Given this list of marker genes AURKA, CPAP, HAUS5, TUBG1, ALMS1, HAUS7, HAUS4, CEP78, CLASP1, CCP110, CEP76, CEP135, NDE1, CEP131, YWHAE, AKAP9, CEP41 (NCBI Gene Id 95681), DYNLL1, CNTRL, CDK5RAP2, TUBB4A, HAUS1, HAUS2, TUBB4B, CEP57, ACTR1A, NINL, PRKACA, NEK2, CEP70 (NCBI Gene Id 80321), YWHAG, CDK1, PLK4, ODF2, CEP192, CSNK1E, CETN2, SSNA1, CSNK1D, DCTN1, PAFAH1B1, MAPRE1, NEDD1, CEP290, PPP2R1A, CEP43, PCNT, DYNC1H1, CEP164, TUBA4A, PCM1 (pericentriolar material 1), HMMR, CEP63, HAUS3, TUBB, HSP90AA1, HAUS8, OFD1, PLK1, DCTN3, HAUS6, DCTN2, PRKAR2B (NCBI Gene Id 5577), CEP250, CEP152, CKAP5, DYNC1I2, TPX2, CEP72 (NCBI Gene Id 55722), TUBA1A, SFI1, SDCCAG8, here is a description of the gene set: Reactome Pathway: AURKA Activation by TPX2 part of: G2/M Transition TPX2 binds to aurora kinase A (AURKA) at centrosomes and promotes its activation by facilitating AURKA active conformation and autophosphorylation of the AURKA threonine residue T288. species: Homo sapiens